The following is a description of a gene set: Reactome Pathway: RHOBTB1 GTPase cycle part of: RHOBTB GTPase Cycle species: Mus musculus This event has been computationally inferred from an event that has been demonstrated in another species.<p>The inference is based on the homology mapping from PANTHER. Briefly, reactions for which all involved PhysicalEntities (in input, output and catalyst) have a mapped orthologue/paralogue (for complexes at least 75% of components must have a mapping) are inferred to the other species. electronically inferred by orthology from the curated human pathway, and this is the list of marker genes: Rbmx, Pde5a, Txnl1, Vim, Cct2, Cct7, Spen